Given this list of marker genes Tcf3, Nlk, Sfrp2, Dkk1, Smad3, Daam1, Dvl2, Rac1, Cxxc4, Wnt4 (NCBI Gene Id 22417), Dab2, Ep300, Lrp1, Fzd4, Runx2, Fzd1, Dvl3, Nkd1, Magi3, Wnt1, Rhoa, Nr5a1, Mapk3, Camk2g, Dlg1, Csnk2a1, Ppp2ca, Sall1, Skp1, Ctbp2, Gsk3b, Hipk2, Dlg2, Ror2, Tbp, Frat1, Axin2, Mark2, Camk2b, Fzd7, Ccnd1, Csnk1a1, Ctnnbip1, Camk2d, Btrc, Brd7, Bcl9, Raf1, Map1b, Fzd6, Dvl1, Akt1, Pin1 (peptidyl-prolyl cis/trans isomerase, NIMA-interacting 1), Pias4, Wnt2, Fzd8, Arrb2, Mapk9, Csnk2a2, Smad4, Cdc25c, Camk2a, Pax2, Lrp5, Arrb1, Mapk8ip1, Ctnnb1 (catenin beta 1), Csnk1e, Fzd9, Sox1, Ctbp1, Axin1, Csnk1d, Wnt3a, Map3k7, Crybb2, Mapk8, Cdh1, Apc, Lrp6, Tcf4, Wnt5a, Frat2, Cdk1, Dlg4, Prkca, Myb, Cul1, Ruvbl1, Tfap2a, Jup, Wnt3, Csnk2b, Fzd5, Lef1, Tax1bp3, Jun, Senp2, Vangl2, Prkcb, Ankrd6, Sfrp1, Mapk1, Sox9, Fzd2, Sumo1, Wnt7a, Fhl2, here is a description of the gene set: studied in species Mus musculus Wnt signaling pathway Mouse Gene Set: WP_WNT_SIGNALING_PATHWAY